The following is a description of a gene set: studied in species Homo sapiens Genes down-regulated in comparison of IgD- peripheral blood B cells versus dark zone germinal center B cells. Human Gene Set: GSE12845_IGD_NEG_BLOOD_VS_DARKZONE_GC_TONSIL_BCELL_DN from publication Longo NS, Lugar PL, Yavuz S, Zhang W, Krijger PH, Russ DE, Jima DD, Dave SS, Grammer AC, Lipsky PE (PMID 19023113) B cells from human tonsil and blood were sorted using flow cytometry. The human samples were processed immediately ex-vivo using markers for known B cell subsets., and this is the list of marker genes: INTS6, NAA16, CSE1L, DNAJB6 (NCBI Gene Id 9186), PHB2, RBM42, MYL6B, GARS1, HLTF (NCBI Gene Id 6596), FARSA, PSPH, PHF7, NAB2, YEATS2, MDH1, ZNF85 (zinc finger protein 85), SKIL (SKI like proto-oncogene, NCBI Gene Id 6498), RHOG (NCBI Gene Id 391), NAT10, CD80, MYO1E, OAZ1, DDX52, EZR, ISG20, ANAPC15, GNRH1, GSTP1, COMMD4, RBM10, MAP4K5, ACTR10, ELAVL1, USP10, TRAIP, FUBP1, POLE, UBE2G1, PARP1, ACTR3 (NCBI Gene Id 10096), NFKB1 (nuclear factor kappa B subunit 1), BAZ2B, PSMC1, CHKA, PDCD11, CNIH1, DEPDC1, AP1G1 (adaptor related protein complex 1 subunit gamma 1), LIG1, CDCA4, NUDT21, MON1B, PLXNB2, RRAS2, COX8A, PFKM, PRKDC, LRCH3, EIF4E, U2SURP, VPS37C, NLK, PEG10 (paternally expressed 10), E2F5, ATP5MF, RUFY3, DDX27, CERK, FBXO46, HIKESHI, ASXL1, SEPTIN2, TOP1, ALDOA, MAP4K1, SPTAN1, NDUFAF7, PNN, BPTF, RPS6KA1, ITPKB, TLCD3A, MRPS16, ASAP1, MYO9A (NCBI Gene Id 80251), URM1, NUDCD3, SERF2, FDPS, PPP1R7, EIF3B, PITPNC1, NASP, NUTF2, LCP1, NKTR, PISD, LNPEP, HNRNPF, ARHGAP26, TUT4, AVIL, OXTR, VGLL4, DCTN5, E2F6, HNRNPM, MFHAS1, MSH2, IPO7, PRDX6, EDRF1, ABR, CTDSP2, ZNF117, RABGAP1L, GRHPR, HMGN1, RGS1, RBBP4 (RB binding protein 4, chromatin remodeling factor, NCBI Gene Id 91125), LHFPL2, PRPF39, RMI1, TFDP1, PCNT, NAXD, SCARB1, MCM5, EGR3, SGMS1, LPIN1, BEX3, WEE1, EIF2B5, PBLD, PMF1, FAS, CHD3, RMND5A, H2BC9, APPL2 (adaptor protein, phosphotyrosine interacting with PH domain and leucine zipper 2), CLCN3, KCNMB3, UBE2S, NFYB, LAGE3, DCTN4, PFAS, SERBP1, MARCKSL1, TCTN1, POLDIP3, CEP76, EDEM1, TUBA3C, YBX1, RANBP1, KDM1A, SNX5, CD22, ZNF195, ZMIZ1 (zinc finger MIZ-type containing 1), ELF4, MTF2, NOL9 (nucleolar protein 9), PPM1G (protein phosphatase, Mg2+/Mn2+ dependent 1G), CSTF3, HPS1, RSRC2, PALS1, RAB11A, RGS10, IFT27, PPAT, RBM23 (RNA binding motif protein 23), SNU13, ABCF1, SNTA1, MBNL1, TEX10, RFC2, CHTOP, ZKSCAN7, SLC43A1, PMCH, EIF4H, RNF8, CD53, GEM, DTYMK, SNX1, VDAC2, LRRC31, CLIP2, RPRD1A, KLHL23, DNAJC10, ZNF254, IL4R